The following is a description of a gene set: Human Gene Set: HP_FACIAL_TICS studied in species Homo sapiens Sudden, repetitive, nonrhythmic motor movements (spasms), involving the eyes and muscles of the face. Facial tics, and this is the list of marker genes: PRRT2, GABRA1, KCNQ3, SCN2A, SCN9A, SCN1B, GABRG2, ATP1A2, SCN1A, PLA2G6, PCDH19, KCNQ2, CACNA1A, PNPT1, TTR